The following is a description of a gene set: Human Gene Set: GOBP_DETECTION_OF_CELL_DENSITY species: Homo sapiens The series of events in which information about the density of cells in a population is received and converted into a molecular signal., and this is the list of marker genes: FAP, PAK1, TSPO, SMO, ATF2, SRPX, DACH1, PTPRJ, CDHR2